The following is a description of a gene set: studied in species Mus musculus Mouse Gene Set: MIR_7067_3P Genes predicted to be targets of miRBase v22 microRNA mmu_miR_7067_3p in miRDB v6.0 with MirTarget v4 prediction scores > 80 (high confidence targets). from publication Chen Y, Wang X (PMID 31504780), and this is the list of marker genes: 1700025G04Rik, Hivep1, Clcn4, Rnf113a2, Serpinb10, Ptf1a, Scp2d1, Gli3 (GLI-Kruppel family member GLI3), Cbln2, Zfp608, Tmem69, Luzp4, Usp31, Neurod4, Inmt, Dyrk1a, Gabarapl2, Cpsf6, Ptprz1, Mindy2, Chd6, Or5d38, Sec63, Rab10, Defb1, Clec12a, Itpr1, Cdk19 (NCBI Gene Id 78334), Nsrp1, Cdk2, Dio2, Gabrb2, Adgrl2, Mpc1, Lrrn1, Virma, Pbx1, Arhgap5, Cd300lf, Cxxc4, Lrch2 (leucine-rich repeats and calponin homology (CH) domain containing 2, NCBI Gene Id 278230), Atxn7, Impg1, Krit1, Tmem273, Fut9, Sesn1, Irf2, Rcn1, Aff4, Senp5, Shtn1, Slc25a13, Usp34, Lin7c, Greb1, Gpbp1l1, Mknk1, Entpd3, Paxbp1, Cryl1, Zfp281, Fbxl3